Given this list of marker genes CCT4, SRC, VCP, SENP5, C15orf48 (chromosome 15 open reading frame 48), HK2 (hexokinase 2), TNIP1, VPS33A, C8orf76, TJAP1, RHOBTB2, PEA15, HLA-A, DYNC1H1, STX3, TMEM199, CISH, STK17A, ZFYVE1 (NCBI Gene Id 57694), DNAJB6, AMPD3, CRIM1, RBM23, BTN1A1, TMED9, TSC22D1, PPP1R10, NMRAL2P, SMPD1, SPHK1, PIR, GPR35, ATP6V1B2, TRIM21, ADAT3, PPIL1, CCDC127, EIF4ENIF1, SDF4, NANS, RC3H2, E2F6 (E2F transcription factor 6), OBI1, SAV1, INO80C, KMO, SERPINB2, ARHGAP31, ERVW-1, RAB13, KEAP1, TINF2, MRPL27 (NCBI Gene Id 64988), HSPA8, DPH3, TINAGL1, R3HCC1L, DYNLL1, LGMN, TM2D2, ERLEC1P1 (endoplasmic reticulum lectin 1 pseudogene 1), PUS7L, WDR93, VPS9D1, MLLT6, BAG3, ZER1, PPRC1, MECP2, PTGR1, METTL1, PCLAF, YIPF6, ZNF677, SCARF1, TRIM56, C1orf122, IL20, IER5, HSP90AA1, KYNU, GSTO1, PTPRK, CXCL1, PAX8, ACSS3, MAD2L1BP, LRRN4CL, GCLM, IGF2R, EYA3, HCP5, MED13, ABCF1, TNS3, GON4L, CES1, NPC1, RHOC, SLC4A4, SERPINB8, ANKRD12 (ankyrin repeat domain 12), ZNF140, NPLOC4, E2F7, IL1A, ZNF267, DUSP5, UBE2A, CYP51A1, ACTR3, CDKN1A, LIG3, ARFGAP3, UBR4, AADAC, EML4, CFAP46, GPRASP3, ZNF200, RALA, GPN2, SEZ6L, SIRPA, SDC4, SP4, NCOA5, PSMD7, FAM120B, ZNF701, SNX19 (sorting nexin 19), C3, LOXL4, OR2A4, CAMSAP2, SQOR, AP3D1, ADPRH, FADD, MED31, RNF185, TSG101, TSSK6, CCRL2, PSMC4, CDH9, SUSD6, SNX9, CTSB, HLA-B, RAD1, MIR3142HG, ZNF189, TRIO, GMEB1, STARD8, NFAT5, NDUFV2, CRNKL1, LRP10, MED12, KCNN4, RUNX1, MOB3C, PSMD14, IL1B, MYO1E, SPAG9, SART3, SRP54, PELO, MFSD2A, CD274, FADS3, SPRYD3, ZNF785, WSB2, PLA2G7, ATP6V1C1, PSMD1, C19orf12, MFAP1, CLCN7, TEX10, HIVEP2, KPNB1, TRIP11, IL2RG, H4C8, TMEM231, TXLNA, PUS3, KLHL21, TNFRSF4, MAMLD1 (mastermind like domain containing 1), PPP1R11, CD63, TNFRSF18 (NCBI Gene Id 8784), here is a description of the gene set: Genes up-regulated in CD4 T cells activated by anti-CD3 and anti-CD28: TGFB1 and IL-12 (2h) versus IL4 (2h). Th1 and Th2 cells arise from a common precursor cell in response to triggering through the TCR and cytokine receptors for IL-12 or IL-4. This leads to activation of complex signaling pathways, which are not known in detail. Disturbances in the balance between type 1 and type 2 responses can lead to certain immune-mediated diseases. Thus, it is important to understand how Th1 and Th2 cells are generated. To clarify the mechanisms as to how IL-12 and IL-4 induce Th1 and Th2 differentiation and how TGF-beta can inhibit this process, we have used oligonucleotide arrays to examine the early polarization of Th1 and Th2 cells in the presence and absence of TGF-beta after 0, 2, 6 and 48 hours of polarization. studied in species Homo sapiens from publication Lund R, Aittokallio T, Nevalainen O, Lahesmaa R (PMID 14607935) Human Gene Set: GSE2770_IL12_AND_TGFB_VS_IL4_TREATED_ACT_CD4_TCELL_2H_UP